Given this list of marker genes Rest, Cyp11b1, Cyp11b2, Cacna1h, Bmp6, Cyp21a1, Wnt4, Bmp5, Dab2, Bmp2, Dkk3, Clcn2, here is a description of the gene set: The chemical reactions and pathways resulting in the formation of mineralocorticoids, hormonal C21 corticosteroids synthesized from cholesterol. Mouse Gene Set: GOBP_MINERALOCORTICOID_BIOSYNTHETIC_PROCESS species: Mus musculus